Given this list of marker genes Pglyrp2, Pglyrp3, Clec12a, Clnk, Havcr2, H2-T23 (NCBI Gene Id 15040), Pglyrp1, Lgals9, Rhbdd3, Pglyrp4, Fgr (NCBI Gene Id 14191), Pibf1, Lilrb4a (NCBI Gene Id 14728), Mill1, here is a description of the gene set: Any process that stops, prevents, or reduces the frequency, rate or extent of natural killer cell activation. Mouse Gene Set: GOBP_NEGATIVE_REGULATION_OF_NATURAL_KILLER_CELL_ACTIVATION studied in species Mus musculus